Given this list of marker genes COX6B1, TAX1BP1, SNHG32, SBDS, SCCPDH, RPS4X, BCAP31, ATP5MG, SGCD, EPS8, SMDT1, CHCHD10 (NCBI Gene Id 400916), UQCRH, NEDD8, PHF1, ILKAP, GPAT4, COX6A1, MCC, PPIA, EIF1, TCEAL4, PGRMC2, SHC4, SUMO3, PLEKHG3, SERPINB6, QDPR (NCBI Gene Id 5860), CCL28, TRIM2, EFNA1, TMEM59, PLEKHB1 (NCBI Gene Id 58473), ST13, HPS5, RAD23A, ABHD12, SIGIRR, SLC66A2, BUD31, ESD, PAIP2, RPS12, BEX3, COA3, PTPN1, CCDC88A, UNK, AP5B1, NUDT3, MAD1L1, ATP6V1E1, PIGA, RAC1, ENPP2, COX5B, CREBL2, NDUFB9, TMCC2 (transmembrane and coiled-coil domain family 2), UBE2E3, MRPL33, RAB1A, EPHX1, WIPI1, APOC1, PABPC1, NDUFC1, PGRMC1, NDUFB10, SPART, MARCKSL1, STARD7, TOLLIP (toll interacting protein), SAT2, ZFAND5 (zinc finger AN1-type containing 5), AMZ2, CCDC154, BTG1, GALM, ADIPOR1, MDH2, CABLES1, NDUFB5 (NCBI Gene Id 96666), MTHFS, RFLNB (refilin B), SRPK2, CNP, SVIP, DEAF1, PDCD6, OSER1, ATP5F1B, TOB1, FAHD2A, ANXA2, FAM210B, ATP5MC3, HMGCS1 (NCBI Gene Id 3157), RBP7, FAAP20, CMC2, HIGD2A, PITHD1, RACK1, BRK1, ARL6IP1, MMP14, PSMB7, ERBB3, HNRNPA0, CCNI, MICAL3, TSC22D4, VAPA, LAMTOR5, FAM167B, BNC2, HEXA, SEPTIN7, CWC15, HINT1, ARL2, MSRB2, ATP6V0A1, MTSS2, SMIM29, RPS28, EXOSC4, DYNLL1, NMRK2, LINC00511, ATP5MF, PLEKHF2, RGS3 (regulator of G protein signaling 3), ARF6, APH1A, MRFAP1, PPP1R37, SAP18, KLF6, HNRNPH3, MRPL23 (mitochondrial ribosomal protein L23), CFL2, COPS9, ICAM1, SPG21, ASRGL1, SLC25A33, EPS15, UBXN1, ARFGAP1, EI24, BAIAP2L1, C19orf12, PAQR8, NDUFA5, LRRN4CL, AP2M1, HNRNPM, ABHD12B, ZNF706, RASGRP3, NIN, TLNRD1, COX7C, TMTC1, IGBP1, CNDP2, C12orf76, ZEB2 (NCBI Gene Id 9839), NUPR1, MPHOSPH8, NCALD, AHCYL2, PRMT2, NDUFS3, SREBF1, SMS, ATP5PO, COX7A2, LYST (NCBI Gene Id 1130), CNBP, COX8A, SMIM10, MAZ, ANKRD28, SOS1, SEC14L1, BSG, CAMLG, SNX2, PPM1B, NDUFS7, NELFCD, TOMM20, CLTA, MRPL44, RBKS, ERP29, CCDC68, TMOD1, PER1, ENDOD1, TMEM109, RHOBTB3, TSPAN14, CDKN1C, MGAT1, COPS8, TMEM51, FBXO7, ZBTB16, PHB1, ARL6IP4, VAMP2, ATP5MK, NINJ1, SKP1, RTTN, ATP5PD, KHDRBS1, LMO4, SMIM26, CSDE1, HES6, PSMA7, PLS3, CDKN2C, RRP1, COX17, CHURC1, NHSL1, TRA2B, YBX1, ARMCX3, TALDO1, SNX27, NDUFS5, EVA1B, HAGHL, ATP5F1A, NDUFA1, here is a description of the gene set: Human Gene Set: GAUTAM_EYE_IRIS_CILIARY_BODY_MELANOCYTES species: Homo sapiens Occular cell types curated from Gautam and Hamashima et al. Multi-species single-cell transcriptomic analysis of ocular compartment regulons from publication Gautam P, Hamashima K, Chen Y, Zeng Y, Makovoz B, Parikh BH, Lee HY, Lau KA, Su X, Wong RCB, Chan WK, Li H, Blenkinsop TA, Loh YH (PMID 34584087)